Given this list of marker genes SCARB1, GUCY1A2, INS, GUCY1A1, THBS1, VEGFA, ENSG00000274276, SPINK1, KDR, CBS, here is a description of the gene set: Any process that modulates the rate, frequency or extent of nitric oxide mediated signal transduction. Nitric oxide mediated signal transduction is The series of molecular signals mediated by the detection of nitric oxide (NO). Human Gene Set: GOBP_REGULATION_OF_NITRIC_OXIDE_MEDIATED_SIGNAL_TRANSDUCTION species: Homo sapiens